Given this list of marker genes TRPC4AP, TRPC1, RIPK3, TRPC3, TRPC5, TRPM7, TRPV4, RIPK1, TRPV3, TRPM6, TRPV5, MLKL, TRPM8, TRPV2, TRPC6, TRPC4, TRPV1 (NCBI Gene Id 7442), TRPM2, TRPM5, TRPC7, TRPV6, TRPM3, MCOLN3, TRPA1, TRPM4, MCOLN2, TRPM1, MCOLN1, here is a description of the gene set: part of: Stimuli-sensing channels Transient receptor potential (TRP) channel proteins were first discovered in Drosophila melanogaster and have many homologues in other species including humans. TRPs form cationic channels that can detect sensory stimuli such as temperature, pH or oxidative stress and transduce that into either electrical (change in membrane potential) or chemical signals (change in intracellular Ca2+ concentration). In humans, there are 28 TRP genes arranged into 6 subfamilies; TRPA, TRPC, TRPM, TRPML, TRPP, and TRPV. Each TRP channel subunit consists of six putative transmembrane-spanning segments (S1-S6) with a pore-forming loop between S5 and S6. These subunits assemble into tetramers to form functional channels. All functionally characterized TRP channels are permeable to Ca2+ except TRMP4 and 5 which are only permeable to monovalent cations such as Na+. Most TRPs can cause channelopathies which are risk factors for many disease states (Nilius & Owsianik 2010). species: Homo sapiens Reactome Pathway: TRP channels